Given this list of marker genes MIR92B, SERPINE1, PHACTR4, SLC2A10, CTNNA1, here is a description of the gene set: Any process that stops, prevents or reduces the frequency, rate or extent of integrin-mediated signaling pathway. Human Gene Set: GOBP_NEGATIVE_REGULATION_OF_INTEGRIN_MEDIATED_SIGNALING_PATHWAY species: Homo sapiens